The following is a description of a gene set: species: Mus musculus Mouse Gene Set: GOBP_POSITIVE_REGULATION_OF_CAMP_PKA_SIGNAL_TRANSDUCTION Any process that activates or increases the frequency, rate or extent of cAMP/PKA signal transduction., and this is the list of marker genes: Spatc1l, Rps23rg1, Adcyap1, Adgrv1, Crh, Mc1r, Gpr3, Calcr, Mif, Ramp3, Adrb2, Gip, Adipoq, Iapp, Ucn